Given this list of marker genes Sema5a, Csnk1a1, Clec4g, Mycbp2, Rora, Cd24a, Pakap, Agfg2, Gja6, Rbfox2 (RNA binding protein, fox-1 homolog (C. elegans) 2), Kcnh8, Snx22, Fbxl3, Cd84, Satb2, 1810009A15Rik, Lsamp, Styk1, Ninl, Ctnna2, Csn1s1, Pitpna, Col4a6, Hecw1, Negr1, Smoc2, Ghitm, Lbhd1, here is a description of the gene set: Mouse Gene Set: MIR_3108_3P Genes predicted to be targets of miRBase v22 microRNA mmu_miR_3108_3p in miRDB v6.0 with MirTarget v4 prediction scores > 80 (high confidence targets). from publication Chen Y, Wang X (PMID 31504780) species: Mus musculus